Given this list of marker genes NFKBIA, NGFR, NGF, SQSTM1, UBC, NFKB1, IKBKB, RELA, TRAF6, RPS27A, IRAK1, UBA52, UBB, here is a description of the gene set: Upon activation in response to NGF, NF-kB moves to the nucleus, where it turns on genes that promote survival, and triggers the expression of HES1/5 to modulate dendritic growth. part of: p75NTR signals via NF-kB Reactome Pathway: NF-kB is activated and signals survival species: Homo sapiens